Given this list of marker genes ID2 (NCBI Gene Id 3398), PPP1CA, OPN5, MTA1, PDE6B, NMU, NR2F6, PPP1CC, ATOH7, AGRP, CRY1, RBM4, PER2, PER1, BHLHE40, PML, FBXL3, AANAT, CRTC1, PPP1CB, USP2, NPY, RBM4B, FBXL21P, PER3, CRY2, CLOCK, SIK1, TP53, here is a description of the gene set: species: Homo sapiens Human Gene Set: GOBP_PHOTOPERIODISM Any process that results in a change in state or activity of an organism (in terms of movement, secretion, enzyme production, gene expression, etc.) as a result of detection of, or exposure to, a period of light or dark of a given length, measured relative to a particular duration known as the 'critical day length'. The critical day length varies between species.